The following is a description of a gene set: studied in species Homo sapiens Human Gene Set: GSE6875_WT_VS_FOXP3_KO_TREG_UP Genes up-regulated in T reg: wildtype versus FOXP3 knockout. To analyze gene expression in in regulatory T cell precursors that develop in the absence of a functional Foxp3 protein as compared to that of normal regulatory T cells from publication Lin W, Haribhai D, Relland LM, Truong N, Carlson MR, Williams CB, Chatila TA (PMID 17273171), and this is the list of marker genes: ACOT9, H3-5, MARCO, NF1, SMAGP (small cell adhesion glycoprotein), TMUB1, GADD45G, BMF, MXI1, PLEKHA2, BRD3OS, NEK7, TMOD3, RAB6B, MLLT6, CCR7, SFT2D1, SNAP29, LGALS1, HSPA12B, TMEM176B (transmembrane protein 176B), VOPP1, BRWD1, STAT4, GAB1, APBB1IP, NCBP2AS2, PCDHA12, CXXC5, MBD2, ANKRD13D, GRK2 (NCBI Gene Id 156), TARS3, NCK2, NCOA3, CLDN10, MRPL2, TCF3, RNF144A, NT5DC1, KIAA0930, CHCHD10, PAK1IP1, DAP, RAP1GDS1, PIK3CG, TRIB2, ANKRD33B, F8A1, MAST1, KMT2E, SPRED2, FGF13, GOLGA3, FMC1, N4BP2L2, L1CAM, FRMD4A, ARHGEF18, SSPN, ITGB3, PGAP1, RAB35, LGI3, SPI1, SLC15A3, RTTN, KCNJ1, AKT2, MAPK11, INTS1, PLEKHO1, INTS4, TNKS1BP1, FLNA, AGO1, PXYLP1, ZBTB22, FAM117B, VIM, PRKD2, ATOX1, APBA3, SIAH1, AMZ2, VPS72, RETREG2, KCNB1, ABHD17B, SMC5, MAPK9, STT3B, ING1, SYCE1L, NNAT, PDAP1, KDM3A, PLCL2, GALNT1, CDR2, MYO9A, CARHSP1, ABCA7, PFN2, PTPRF, STK26, MAN1A2, CNN2, CKAP4, POLR1F, EHD4, COL27A1, IDI1, ZBTB2, MOXD1, NELFA, SHF, AKAP12, RGL1, MYH6, ZNF821, SAP30L, TREML2, POLD1, ETV5, RHOA, PIP5K1B, LLGL1, LCK, LSP1, MPP4, HLA-DQA1, DIPK1A, REEP5, AQR, BBS9, FBXO34, OTULIN, SBK1, NADK2, SAMHD1, TMPRSS11A, LBR, TRIM25, DCAF10, POLE4 (DNA polymerase epsilon 4, accessory subunit), RALGAPB, SLC25A25 (NCBI Gene Id 114789), SEC63, ABCB7, NAGS, ZBTB33, SNX29, PTBP3, SMC4, ZBTB7B, LRRC75A, RASA3, CHIC2, SPAG9, ZNF474, GPR174, SDC1, RAP1B, EMSY, PIK3AP1, CFAP263, PRRC2B, MTSS1, PITPNC1, FNDC8, COL25A1, APBB1, LTB, DCLK3, ACACA, ART5, ADAMTS6, PI4KA, PCMT1, HSD17B7, CARD19, PPP1R2P1, FDPS (farnesyl diphosphate synthase), TRIR, MANF, IGKC, SLC25A24, ARFGAP1, BAIAP2, SPTAN1, ARF4, VPS8, DNAJC13, HECW2, SAP30, NSMCE4A, SEC24D, ATP6V0B, ALCAM